Given this list of marker genes COQ10A, ARPC1A, PNPLA8, MAU2, LINC00581, MIR4279, EIF3D, NHLRC4, VGLL3, ARAP1, GABPB2, GAS8, MIX23, KLRK1, CCIN, RYR3, USP30, SMG1P3, TARS2, RRM1, GUSBP1, CUL4AP1, LINC01641, TMUB1, ALOX12B, ZNF283, ABCC9, MDH1, GSTO2, DCUN1D4, PPP2R5A, UTP4, WWC1, LINC00680, NME9, INKA2, SPNS1, ZNF219, AMER1, NLE1, RN7SKP270, LRRC63, THOC6, YAE1, MAGT1, TOR1AIP1 (torsin 1A interacting protein 1), LGMN, LYPLA2P1, CHFR-DT, DNAJC11, AURKAIP1, PPIP5K2, C1orf87, DVL2, LUZP1, ZNF548, MTFMT, GUSBP2, SLC24A1, ARIH1, NDC1, MAP4, SLX4IP, SARM1, SLC25A16, BTF3-DT, CDCA7P1, ENSG00000244137, TRIM9, ENTPD1-AS1, RAD54B, TMEM41B, FBXO31, ARMH3, RNA5SP474, JMJD6, PIGQ, FNBP1P1, TICRR, LINC01485, OR1X5P (NCBI Gene Id 403233), TNFRSF12A (NCBI Gene Id 51330), EIF1AD, CIBAR2, POMT2, GTF2I, STX18 (syntaxin 18), ATG5, SYCE2, SRRM3, CRADD, ENPP3, ZNF829, GALNTL5, SBNO2, ZSWIM4, TRIM55, NANOGNB, JAZF1-AS1, UQCC3, CWC25, RFWD3, SPESP1, WEE2P1, ADD3, TTLL13, INVS, GDI2, GNAS-AS1, RPL7AP6, CYP1B1-AS1, SNAP47, RNU6-847P, STX4, ZNF280B (NCBI Gene Id 23748), NAE1, TUBA1B, BOD1, MRPS22, CTB-30L5.1, LINC02044, INTS7, USP39, CDK5R2, TAGAP-AS1, MAP1LC3B, SUMO1, RPPH1, SDAD1P3, UQCRH, NOL11, RPL10, SIRT2, ZSCAN21, ZRANB3, ZBTB7C, BTF3, PES1, RCCD1, ARL8B, CMPK1P2, RNU6-386P, EFCAB7, PALMD, ALDOA, ARID1A, NUCB1-AS1, LRRC40, HEXA, RPL36P9, NSUN2, PCGF1, TMEM274P, COPS3, CHFR, AURKB, TRPC4, LINC00992, UBE2G1, IQCH-AS1, BRIP1, NCKAP1L (NCBI Gene Id 3071), SLC22A11, PPAN, ABHD17A, RGS5, NOL6, CDH22, JMJD4, TSC22D4, RCCD1-AS1 (RCCD1 and UNC45A antisense RNA 1), LINC01235, SCN3B, PUM3, ZNF226, RASA4EP, CCNJ, TTC1, WDPCP, MIR3162, ZNF688, FMN2, MTF2, MYO9B, PYCR3, LIN28B, CCDC186, MIR5188 (microRNA 5188), EGLN3, WNT8A, ADD3-AS1, PHF19, SLC44A1, AFG1L, MDC1, ZDHHC4, TRAPPC14, CLN3, GRN, SRD5A1, GXYLT2, ADA, RND1, BANF1, GIN1, EVA1C, SNHG29, PRKG2, MTO1, WDR11, AMN1, PRDM9, ZNF568, NPHS1, HAGH, FOXK2, ZNF540, SLC25A21, SRSF11, MIR4482, ANP32A, NFKBIB, STK33, STAG2, CASTOR3P, CORO1C, TCP11L2, STAT2, EIF2D, CLK4, BRK1, LCORL, AACS, ZNF675, ABCA7, SLC39A7, PMM1, TRAF7, NR4A1, SAR1A, NONO (NCBI Gene Id 8253), UBA5, SSX7, RAI1, IFI44L, GIT2, TMPOP2, WDR11-DT (NCBI Gene Id 283089), INTS1 (integrator complex subunit 1), TMEM177, QSER1, LRRC41, RN7SL93P, LYN, LINC02298, MRPL39, SNTB2, PARS2, KIF13A, PLA2G15, SCAMP1, WASF1, SNHG30, BUB1B, SH2B3, MIR3908, ZFYVE27, MRPS33, H2AC21, RNU6-607P, RNF6, HCFC1R1, MB, DNAJB9, GCLC, LOXL2, LINC00240, THAP5, COIL, ORAI3, SUGP1, RPL29, SLFN12, HAUS8, CDIP1, UBC, DRAP1, TRDMT1, VPS39, EPPK1, TBL2, EXOSC2, ITGA7, KRCC1, AIFM1, ALKBH2, ARVCF, ZNF638, RNU6-1003P, LINC01556, GSK3A, ANGEL1, NUMA1, KRT8, JHY, DAGLB, ST3GAL2, PDZD2, PRMT3, STARD10, PPAN-P2RY11, RRN3P1, ZNF585B, C6orf141 (NCBI Gene Id 135398), RSPH3, HEBP2, RNU6-166P, ZNF274, TGFB1, PTPN2, TYK2, MTND1P14, FRMD7, MED21, GLRX5P2, ST7, HEXA-AS1 (HEXA antisense RNA 1), TPRXL, VPS50, BBLNP1, FOCAD, CENPM (NCBI Gene Id 79019), SNORD49B, ENSG00000260592, DKKL1, JPX, DUS2, NBEA, ZNF586 (zinc finger protein 586), SPMIP10, SMAD1, LRRC51, SDC4, ZNF697, GATAD2A, SUZ12P1, SMG8, AKAP9, P3H2-AS1, CROCCP3, RFX5, MED23, LMCD1-AS1, C11orf68, SLC6A1, VTN, TRIM15, BCAR3, MAP4K5, FCHO2, ANGPTL6, PRKCG, ELK1, CD160, LBHD1, RORA, CDC42SE1, NEUROD2, CLN5, CCDC159, BMS1, DHRS7B, NEU1, LTK, RFC1, ZNF441, APLP1, P3H2 (NCBI Gene Id 55214), BLOC1S1, NUF2, C11orf65, RPS16P9, TRAV15, PA2G4, WTAPP1 (NCBI Gene Id 100288077), TCEAL8P1, ZC3HC1, ZFP30, MARCHF8, ENSG00000232995, NAGA, ENSG00000233017, IFT88, RN7SL403P, PAK5, SOX9-AS1, GSN, TCF7L2, LL22NC01-81G9.3, MET (MET proto-oncogene, receptor tyrosine kinase), LCP1, CLDN23, FBXO33, ZNF395, ACER3, FABP5P3, ADCY4 (adenylate cyclase 4), CDK4, SNORD49A, URB2, YAE1-DT, IFTAP, BORCS6, PSMC1, INTS14, ALOX15P1, MKKS, LINC02390, SLC7A5P2, HNRNPMP2, LINC02916, DHTKD1, ZNF331, FAM234B, XPOT, XXYLT1, WDR70, BRWD1, EEPD1, BFSP1, ACAD11, EMSY-DT, ENSG00000266767, EMSY, RPL36, HAPLN2, NIHCOLE, RB1CC1, MAP3K7, LYPLA2, KRBA2, ITGAL-AS1 (ITGAL antisense RNA 1), EEF1DP3, PAFAH2, AP1S3, NAPSA, RPS12, NDUFS7, OGG1, PRPF18, ESPN, STARD13, H4C1 (H4 clustered histone 1), TM7SF3, FHL1, VOPP1, LIM2-AS1, STX18-AS1, ASS1P5, TMEM150A, RBBP5, MRPS31, MPHOSPH8, CYB5B, ABCF3, ARHGEF39, SMARCA5-AS1, TPM4P1, TDRD3, COLGALT1, TNFRSF10B, MKRN2, GNGT1, KAT8, RNA5SP283, LIPA, ZNF875, CDON, ZNF217, TBPL1, SCRN3, FAM117B, RFTN1, PDZD7, RNU6-1340P, MLST8, SMARCD2, TAF5L, HMGN3, TCEANC, MORF4L1P5, GLG1, CFAP299, CDC40 (cell division cycle 40), KCNN1, BCAS3, SNORD101, KCTD14, PCAT19, FES, HACD2, RHPN2, DNAI4, HERC5, ISLR2, CCT6B, DLL3, ARHGEF3, SNAP25, RABEP2, SPAG1, LYPD5, GUSBP11, SPINK9, DCP1A, H3P10, ALG1L1P, ITGB3BP, ENO1-AS1, RNU4-62P, ERP44, IL16, TUBA1B-AS1, RPLP2, PIPOX, CMKLR2-AS, KRT18P45, ENSG00000265246, ITCH, SPATS2L, LINC03059, ACACA, RPL32P27, CCDC65 (NCBI Gene Id 85478), MYLK-AS1, COPS5P1, TBC1D14, SLC7A2, CATSPERG, SLC39A3, here is a description of the gene set: species: Homo sapiens Genes containing one or more binding sites for (ZNF577) in their promoter regions (TSS -1000,+100 bp) as identified by GTRD version 20.06 ChIP-seq harmonization. Human Gene Set: ZNF577_TARGET_GENES from publication Yevshin I, Sharipov R, Kolmykov S, Kondrakhin Y, Kolpakov F (PMID 30445619)